Given this list of marker genes Grin2b, Nos1, Adcy8, Mir374b, Gip, Shank2, Mir181a-1, Mir218-1, Eif2ak4, Mir541, Lgmn, Mir770, Dbi, Mir128-1, Mir421, Mir124a-1hg, Mir411, Adcy1, Psen1 (NCBI Gene Id 19164), Pak1, App, Mir98 (microRNA 98), Mir28a, Rgs14, Cpeb3, Nsg1, Epha4, Shisa7 (NCBI Gene Id 232813), Snap47, Mir338, Enpp1, Mir191, Grin2d, Lrrtm1, Mir145a, Vamp2, Mirlet7e, Mir138-2, Mir434, Mir337, Mir100, Mir137 (microRNA 137), Mir379, Reln, Htr6, Mir1983, Prkcz, Mir672, Nfatc4, Mir99a, Mir382, Mir132, Mir342, Mir93 (NCBI Gene Id 723885), Mir148b, Arc (activity regulated cytoskeletal-associated protein), Mir9-3 (microRNA 9-3), Mir26a-1, Igsf11 (immunoglobulin superfamily, member 11), Mir540, Mir9-1, Snca, Mir138-1, Mir127, Mir467a-8, Mir222, Mir467a-1, Mir467a-4, Mir433, Mir204, Mir467a-9, Mme, Mir551b, Apoe, Mir195a, Gria3, Mir20a, Mir383, Fmr1, Shank3, Slc24a1, Mir872 (microRNA 872), Ptk2b, Mir9-2, Syt12, Mir487b, Mir674, Mir134, Mir760, Pde9a, Nf1, Mirlet7d (microRNA let7d), Mir673, Mir345, Paip2, Mir126a, Mir324, Crhr1 (corticotropin releasing hormone receptor 1), Mir369, Mir500, Slc18a3, Nlgn3, Nlgn1, Mir467a-2, Tshz3, Plk2, Adora2a, Stx3, Crtc1, Mir218-2, Ntrk2, Gsk3b, Mir467a-10, Ckap5 (NCBI Gene Id 97044), Mir92b, Mecp2, Mir320, Nr2e1, Mirlet7f-1, Gria1, Slc24a2, Mir181c, Mir92-1, Mir30e, Mir501, Nptn, Prnp, Mir106b, Slc1a1, Mir106a, Mir101b, Mir15a, Lrrtm2, Mir467a-3, Fam107a, Stx4a, Adrb1, Mir652, Mir17, Mir25, Mir467a-6, Mir151, Ythdf1, Nrgn, Mir384, Mir23b, Ncstn, Mir378a, Drd1, Grin2c, Mir7-1, Mir667, Mir92-2, Cx3cr1, Ppp1r9a, Chrd, Ptn, Abl1, Mir300, Mir153, Fxr1, Slc8a3, Camk2b, Mir149, Slitrk4, Grin2a, Mir30d, Mir29b-1, Serpine2, Mir22, Mir29a, Hnrnpk, Tyrobp, Zdhhc2, 2510002D24Rik, Pirb, Sqstm1, Mir484, Mirlet7c-1, Braf, Mir328, Mir467a-7, Mir381, Mir467b, Drd2, Hmgcr, Rab3a, Mir7b, Mir124-2hg, Chrna7, Mir26a-2, Itpr3, Ephb2, Ptpn5, Crhr2, Mir19b-2, Mir410, Mir539 (NCBI Gene Id 723917), Mir125b-1, Mir128-2, Pten, Large1, Mir467a-5, Mapk1, Mirlet7i, Mir19b-1, Mir30a, Crh, Slc8a2, Cyp46a1, Snap25, Cc2d1a, Prkar1b, Mir7-2, Mir744, Mir181b-1, Ager, Mir125a, Rims1, Prrt1, Mir425, Musk, Mir211, Mirlet7c-2, Mirlet7f-2, Akap5, Mir23a, Rasgrf2, Mir24-1 (NCBI Gene Id 387184), Mir125b-2, Mir19a, Mir301b, Mir221, Mir26b, Mir30c-2, Nog, Adora1, Mir30c-1, Mir150, Htr7, Mir130a, Mir181d, Mir486, Stau1, Creb1, Mir30b, Mir181b-2, Mir24-2, Gfap, Mir129-1, Mir187, Unc13a, Mir29b-2, Mpp2, Mir181a-2, Mir330, Prkcg, Tnr, Mir129-2, Mir101a, here is a description of the gene set: A process that modulates synaptic plasticity such that synapses are changed resulting in the increase in the rate, or frequency of synaptic transmission at the synapse. studied in species Mus musculus Mouse Gene Set: GOBP_LONG_TERM_SYNAPTIC_POTENTIATION